The following is a description of a gene set: from publication Litvak V, Ramsey SA, Rust AG, Zak DE, Kennedy KA, Lampano AE, Nykter M, Shmulevich I, Aderem A (PMID 19270711) Genes down-regulated in comparison of unstimulated macrophage cells versus macrophage cells stimulated with LPS (TLR4 agonist) for 120 min. The innate immune system is a two-edged sword; it is absolutely required for host defense against infection, but if left uncontrolled can trigger a plethora of inflammatory diseases. Here we used systems biology approaches to predict and validate a gene regulatory network involving a dynamic interplay between the transcription factors NF-κB, C/EBPδ, and ATF3 that controls inflammatory responses. We mathematically modeled transcriptional regulation of Il6 and Cebpd genes and experimentally validated the prediction that the combination of an initiator (NF-κB), an amplifier (C/EBPδ) and an attenuator (ATF3) forms a regulatory circuit that discriminates between transient and persistent Toll-like receptor 4-induced signals. Our results suggest a mechanism that enables the innate immune system to detect the duration of infection and to respond appropriately. Human Gene Set: GSE14769_UNSTIM_VS_120MIN_LPS_BMDM_DN species: Homo sapiens, and this is the list of marker genes: FKBPL, CLN3, DENND4A, CCDC71L, SELE, PARP14, ATF3, STAT5A, SDC4, BTG2, RRS1, DNAJA2 (NCBI Gene Id 9237), CD69, NLRP3, VASP, IKBKE, SENP6, AOC3, MTMR12, C11orf96, PCDH7, IFIT1B, FABP4, SLAMF7, OTULIN, CITED2 (Cbp/p300 interacting transactivator with Glu/Asp rich carboxy-terminal domain 2), BMP2, SGMS1, ZNF131, PLAUR, CSF1, SLC16A10, FNBP1L, ABRACL, CSRNP1, TBC1D1, FILIP1L, OAF, HBEGF, SPRYD7, ST3GAL1, RSAD2, CCL13, SLC31A2, ADAM17 (NCBI Gene Id 6868), BORCS6, TMEM39A, IER2, RASA2, FZD5, MED21 (NCBI Gene Id 96839), MCOLN2, SERP1, SLC3A2, NAMPT, NRIP1, TTC39C, NUPR1, GTF2B, EBI3, ZNF263, OPTN, TIPARP, AHNAK, KCTD12, NFIL3, SLC7A11, AKNA, FRMD6, HERPUD1, GSDMA, RFFL, ID3, ZNF81, CCNG2, CLN5, VASH1, OTUD1, SLC30A4, SLC44A1, CSF2, SOCS7, FBXW11, GJA1, CDK12, MAP2K3, IRF4, B4GALT5, DUSP1, DYRK2 (NCBI Gene Id 8445), STX3, ELL2, SLC25A37, TANK, HLA-B, NDEL1, FAM20C, RGS3, IRF5, GNA13, EGR2, HIF1A, SOCS5, NCK1, ZBTB7A, LRRN1, HIPK1, CD274, SLC15A3, G3BP1, TLK2, RAB12, RPS6KA2, SIAH2, COQ10B, C15orf48, B3GNT2, RNF103, SRGN, RBM7, GPR174, EGR1, MCL1, GRIA2, SPRED1, SDE2, KATNA1, ZNF800, PPP1R10, ARF4, DUSP2, SAP30, RHBDF2, VCAM1, TNFRSF12A, HILPDA, MAP4K3, MAPK6, PDGFB, APAF1, SLC7A2, CLIC4, ARG2, FABP3, DCUN1D3, BCL6, MKI67, FRS2 (fibroblast growth factor receptor substrate 2), CD74, KLF7, IGSF6, SERPINE1, CCNL1, CXCL2, LPIN2, ZNFX1, CLEC4D, IRF1, ISG15, TNIP1, IL10, PIP5K1A, USP16, EDN1, IL1RN, PPP2R2A, TGM2, TMEM171, ZNF281, SP110, DCBLD2, TFEC, C9orf72, CTU1, ID2, CCL17, GMEB2, PDE1B, IFIH1, DUSP14, GPR132, BCL2A1, HIVEP1, AREG, MAPKAPK3, SNX10, ANKRD33B, PTH1R, KDM6B, ZFP36, IRAK2, FEM1C, PLAGL2, EGR3, MARK2, GBP4, ARID5A, C3, BHLHE40, MT2A